The following is a description of a gene set: Human Gene Set: GSE22611_NOD2_TRANSD_VS_CTRL_TRANSD_HEK293_MDP_STIM_2H_DN Genes down-regulated in HEK293 cells at 2h after stimulation by muramyl dipeptide: over-expressing mutant NOD2 versus control. NOD2 is an intracellular receptor for the bacterial cell wall component muramyl dipeptide (MDP) and variants of NOD2 are associated with chronic inflammatory diseases of barrier organs e.g. Crohn disease, asthma and atopic eczema. It is known that activation of NOD2 induces a variety of inflammatory and antibacterial factors. The exact transcriptomal signatures that define the cellular programs downstream of NOD2 activation and the influence of the Crohn-associated variant L1007fsinsC are yet to be defined. To describe the MDP-induced activation program, we analyzed the transcriptomal reactions of isogenic HEK293 cells expressing NOD2wt or NOD2L1007fsinsC to stimulation with MDP. Importantly, a clear loss-of-function could be observed in the cells carrying the Crohn-associated variant L1007fsinsC, while the NOD2wt cells showed differential regulation of growth factors, chemokines and several antagonists of NF-κB, e.g. TNFAIP3 (A20) and IER3. from publication Billmann-Born S, Till A, Arlt A, Lipinski S, Sina C, Latiano A, Annese V, Häsler R, Kerick M, Manke T, Seegert D, Hanidu A, Schäfer H, van Heel D, Li J, Schreiber S, Rosenstiel P (PMID 21335489) species: Homo sapiens, and this is the list of marker genes: MMP21, IFNA13, C14orf39 (NCBI Gene Id 317761), CNMD, MUSTN1, SHD, SMAD6, APOBEC4, SH3GL3, MIR539, SLC6A5, SLC6A19, GAS2L2, TMOD4, CALN1, PRSS3, CADM4, DRC3, TMEM130, CLSTN2, SRMS, FAM180A (NCBI Gene Id 392794), CLMN, ARTN, MIRLET7B, KCTD4, ACVR2B, ZC2HC1B, IL11, GNAL, CACNA1C, VSTM2A, PRAMENP, LRRC56, DCX, BVES, DSG2 (desmoglein 2), NDRG4, DLG2, LECT2, ADCY1, ELANE, ATP8B1, CPLX2, MAT1A, TEKT4, IL3, AICDA, HECTD2, UTS2, KCNIP3, KSR2, RIPPLY3, SLC27A3, HEPH, ZNF235, AANAT, TULP1, FER1L6, GRIN3A, KCNA3, MUC4 (mucin 4, cell surface associated), MMEL1, DPYS, DRGX, C2CD6, MYO18B, CBY3, CRHR1, CCR8, MYOM2, DYDC1 (DPY30 domain containing 1, NCBI Gene Id 414183), FGF4, RESP18, GABRG1, ROS1, ODAD2, NXF3, ADCYAP1R1, RAB39B, MARK1, HOXA7, RHBDL3, CAMKK1, KRT84 (NCBI Gene Id 3890), ILDR1, MSLNL, WNK4, GNAZ, ODF4, LRIT3, HS6ST2 (heparan sulfate 6-O-sulfotransferase 2), BTC, ABO, TMT1B, FCRL6, RGS13, LRRC37A, KCTD19, SYN3, P2RX5, CELSR3, GIPC2, ASB15, TRPC5, FMO3, PIK3R3, CHRM5, SLC25A31, PLA2G4F, DUSP21, PCDH11X, MIA, FAM178B, KCND3, IQUB, ZBBX, SH3BP4, HOXA11, TMEM207, KREMEN2, ENPEP, SCG3, CNIH2, NPC1L1, PAQR6, NGRN, SLC6A14, SYNDIG1, ANKLE2, SUN5, USP13, JPH1, NAT8L (NCBI Gene Id 339984)